Given this list of marker genes KRT14, MMP1, COL7A1, LAMA3, DSG3, COL17A1, ITGB4, ITGA6, LAMC2, PLEC, HLA-DRB1, KRT5, HLA-DQB1, LAMB3, here is a description of the gene set: species: Homo sapiens Blisters arising in the mouth. Human Gene Set: HP_ORAL_MUCOSAL_BLISTERS Oral mucosal blisters